The following is a description of a gene set: part of: Neurotransmitter release cycle species: Mus musculus Reactome Pathway: Dopamine Neurotransmitter Release Cycle electronically inferred by orthology from the curated human pathway This event has been computationally inferred from an event that has been demonstrated in another species.<p>The inference is based on the homology mapping from PANTHER. Briefly, reactions for which all involved PhysicalEntities (in input, output and catalyst) have a mapped orthologue/paralogue (for complexes at least 75% of components must have a mapping) are inferred to the other species., and this is the list of marker genes: Lin7b, Rab3a, Ppfia2, Syn1, Cplx1, Syt1, Stx1a, Ppfia3, Syn3, Vamp2 (vesicle-associated membrane protein 2, NCBI Gene Id 22318), Tspoap1